The following is a description of a gene set: studied in species Homo sapiens Human Gene Set: GOBP_VESICLE_TARGETING_TO_FROM_OR_WITHIN_GOLGI The process in which vesicles are directed to specific destination membranes during transport to, from or within the Golgi apparatus; mediated by the addition of specific coat proteins, including COPI and COPII proteins and clathrin, to the membrane during vesicle formation., and this is the list of marker genes: AP1AR, TMED10, TRAPPC1, WIPI1, PPP6C, TMED9, TMED2, TRAPPC4, TRAPPC2L, TFG, TRAPPC2, ARFGAP3, TRAPPC2B (NCBI Gene Id 51587), KLHL12, SAR1B, TRAPPC11, CEP19, PREB, ARFGAP2, PEF1 (NCBI Gene Id 553115), TRAPPC6A, CSNK1D, TRAPPC5, SAR1A, CUL3, MAPK15, PDCD6, GBF1, TRAPPC12, SEC16A, TRAPPC8, TRAPPC3